The following is a description of a gene set: Human Gene Set: GOCC_COMPACT_MYELIN The portion of the myelin sheath in which layers of cell membrane are tightly juxtaposed, completely excluding cytoplasm. The juxtaposed cytoplasmic surfaces form the major dense line, while the juxtaposed extracellular surfaces form the interperiod line visible in electron micrographs. studied in species Homo sapiens, and this is the list of marker genes: NCMAP, MARVELD2, MBP, PTEN, MAL, SIRT2, CLDN5 (NCBI Gene Id 7122, claudin 5), CLDN19, PMP22, PLLP, PALS1, MAG, PRKCI, ANXA2, JAM3